The following is a description of a gene set: The process that results in the patterns of cell differentiation that will arise in an embryo. Human Gene Set: GOBP_EMBRYONIC_PATTERN_SPECIFICATION studied in species Homo sapiens, and this is the list of marker genes: GDF3, SATB2, DLL1, NRP2 (NCBI Gene Id 8828), RIPPLY2, STIL, CRIPTO, SMAD4 (SMAD family member 4), ZBTB16, TDRD6, EFNB1, MEIS2, TASOR, IHH, NRARP, TBXT, PLD6, NODAL (nodal growth differentiation factor), PGAP1, ERBB4, WNT1, TBX3, MEIS3P1, MEIS3, WNT5A (NCBI Gene Id 7474), MEIS1, MEOX1, WNT7A, SIM2, MESP1, CXXC4, NEUROG1, MEOX2, SMAD6, MESP2, COBL, PCSK6, CDX2, FZD5, DISP1, LAMA5, SEMA3F, BASP1, DCANP1 (dendritic cell associated nuclear protein 1), DOP1B, BMP7, NCKAP1, WT1, SMAD5, CDX1, PTCH1, TDRD7, TBX6, NRP1, EPB41L5, TIFAB, SHH, TDRKH, RIPPLY3, CDX4, TMED2, FGFR2, CHRDL1, LHX1, TDRD1, TDRD5, ZIC3, C2CD3, SMAD1, CTNNB1, SMAD2, NOTO, HOXD8, SMAD3, RIPPLY1, FGF10, FRS2, OOEP